Given this list of marker genes Rnf19b, Calhm6, Irf7, Clec4n, Parp12, Cebpb, Basp1 (brain abundant, membrane attached signal protein 1), Mt2, Il1a, Ifi203, Batf3, Sod2, Noc4l, Junb, Irf8, Ifi205, Daxx, Samhd1, Irgm2, Gimap5, Nabp1, Arl4a, Irgm1, Tfec, Ifi206, Batf2, Rrs1, Ubd, Arid5a, Slfn5, Ifi47, Rars1, Gch1, Psmb9, Igtp, Hilpda, Gbp5, Max, Bach1, Dtx3l, Il10ra, Ifi211, Atf3, Cxcl9, Mndal, Lap3, Socs1, Gbp7, Nop58 (NCBI Gene Id 55989), Ptpn1, Txn1, Gng11, Ilrun, Ccl12, Plekho2, Themis2, Tnfaip2, Ccdc25, Psma3, Rnasel, Ccl7, Trappc6b, Fam241a, Zbp1, Serpina3f (serine (or cysteine) peptidase inhibitor, clade A, member 3F), Gbp2b, Cacybp, Ccl2, Trim30a, Fcgr4, Eif2ak2, Csde1, Osgin1, Cxcl10, Ifit2, Sumo2, Tma16, Irf1, Cd274, Cebpd, Glipr2, Maff, Cdkn1a, Iigp1, Litaf, Btg1, Bcl2a1a (NCBI Gene Id 12044), Pim1, Pnp, Clic4, Scimp, Etf1, Serpina3g, Lcp2, Parp9, Rsl24d1, Eef1e1, Socs2, Rap2c, Apol7c, Rbms1, Sp110, Fcgr3, Gbp2, Socs3, Stat1, Gnb4, Slfn2, Zyx, Trim30c, Ifi204, Isg15, Nampt, Bcl2a1b, here is a description of the gene set: species: Mus musculus Genes positively differentially expressed in cell type: Macrophage upon treatment with cytokine: IL-18 in mouse lymph nodes in vivo. Cytokines mediate cell-cell communication in the immune system and represent important therapeutic targets. A myriad of studies have highlighted their central role in immune function, yet we lack a global view of the cellular responses of each immune cell type to each cytokine. To address this gap, the authors created the Immune Dictionary, a compendium of single-cell transcriptomic profiles of more than 17 immune cell types in response to each of 86 cytokines (>1,400 cytokine-cell type combinations) in mouse lymph nodes in vivo. A cytokine-centric view of the dictionary revealed that most cytokines induce highly cell-type-specific responses. For example, the inflammatory cytokine interleukin-1β induces distinct gene programmes in almost every cell type. A cell-type-centric view of the dictionary identified more than 66 cytokine-driven cellular polarization states across immune cell types, including previously uncharacterized states such as an interleukin-18-induced polyfunctional natural killer cell state. Mouse Gene Set: CUI_MACROPHAGE_IL18_RESPONSE_UP from publication Cui A, Huang T, Li S, Ma A, Pérez JL, Sander C, Keskin DB, Wu CJ, Fraenkel E, Hacohen N (PMID 38057668)